The following is a description of a gene set: Genes having at least one occurrence of the motif CKSNYTAAAAAWRMCY in the regions spanning 4 kb centered on their transcription starting sites. This matches the transcription factor binding site V$MMEF2_Q6 (v7.4 TRANSFAC). Human Gene Set: MMEF2_Q6 species: Homo sapiens, and this is the list of marker genes: LINC03040, DNAJA4, BCL6, ARL4C, KLHL40, CYP26B1 (cytochrome P450 family 26 subfamily B member 1), KIRREL3, FGF13, RIMS2 (regulating synaptic membrane exocytosis 2), CRHBP, RCOR1, EHD4 (EH domain containing 4), GEN1 (GEN1 Holliday junction 5' flap endonuclease), HAS2, WFDC1, NANOS1, FXR1, COX7A2, BCL9L, EYA1, RBM8A, EBLN2, SSPN, RTP1, RTN1, MPC2, ZNF436-AS1, MYO15A, GRIK1, LINC00474, ESR1, SLC39A13, P2RX5, TLE3, RHOBTB1, FOXP2, KPNA3, ELAVL4, HOXA10, TNNC1, TENT5A, ADAM11, TYRO3, USP2, PRX, SH3BGRL3, TCTA, CKM, ARHGAP12, NOX3, MANF, CLDN14 (claudin 14), DUSP14, POU2F1, POU3F2, SLC26A9, SEMA3A, CLASP1, CACNB3, MCTP1, SLC38A3, TSPEAR, HMGB4 (NCBI Gene Id 127540), TP63, MEPCE, ARHGEF15, DMD, LRRTM1, TM2D3, DLG2, TFAP2D, DLGAP4, GAL3ST3, HS3ST5 (heparan sulfate-glucosamine 3-sulfotransferase 5), ANKMY2, CAPN1, ZNF436, ATXN7L1, USP13, MYL1, HIVEP3, CALCR, HOXD8, HIBADH, CACNA2D3, ASCL4, ZNF516-DT, TACR1, WIPI1, WDR81, NIPBL, COLQ, ASIC2, BEGAIN, LINC01597, ZCWPW1, CASQ1, IKZF2 (NCBI Gene Id 51173), NFIL3, UBE2F, HOXA4, FOXD3, H1-5, LUZP1, ACVR2A, PACSIN3, LHX9, VANGL1, TFDP2, EHD1, ADAMTS9, LRRN3, ADGRB3, LUC7L, ATL2, DNAJA2, PRKAG1, LINC00670, ABCB4, TUBA4B, TCEA3, FGF9, ACTG2, LMO3 (LIM domain only 3), DCTN1, HMGN2 (NCBI Gene Id 94860), GSC, HNRNPL, INPPL1, TLCD5, INSIG2, GCAT, ZMYND8, TSPAN14, RALY, GNB4, MYB, RBM12B, CSNK1E, CA7, ADGRL2 (NCBI Gene Id 23266), SALL3, CBFA2T2, SOBP, FILIP1, MYL11, SOX3, PDLIM1, CYB561D1, JUNB, ZPBP2, GET4, NCAN, HSPB7, VSTM2L, NRP2, KCNJ13, SALL1, PRRT2, TENM3-AS1, MYH6, ARHGAP36, FHOD1, MITF (NCBI Gene Id 7487), PIP4K2C, SLC12A5, SDC1, LYN, CHN2, MAFA, DIP2B, SIN3A, RUNX2, PPP1R16B, FOXA2, DMPK (NCBI Gene Id 60405), ADD3, BHLHE40, SSH3, ACTA1, OLIG3, PRDM13, CFL2, PENK, MAS1, HOXB8, HOXC10, TOPBP1, TUBA4A, CPS1, BNC2, CLDN23, SOX14, AMBN, MBNL2, LMX1A, BHLHE22, RFX3, MYOZ2, PTCHD4, GPR15, DBNDD2, CRTAP, STAG2, DNAJB5, ATP6V0C, DHRS3, RHOA, HSPB1, MYL6B (NCBI Gene Id 140465), GABRA1, B3GLCT, HOXD4, SLC50A1, NRAP, ZDHHC8, PRMT3, ASPH, E2F8, FAM241A (NCBI Gene Id 132720), MYL2, ELMO3, ZNF385B, NR2F1, COL11A2, SLCO2A1, GAN (NCBI Gene Id 8139), BZW2, NOG, MAB21L2, ARHGAP26, SIX3, FLRT3, ELAVL2, TOMM70, SMPX, B4GALT1, FLT1, HOXB6, PPP2R2B, MYO3B, NLK, HOXA11, CDKL5, TBR1, NEDD4, DGKI, PRKCQ, GAPDH, CDC42EP3, HTR2B, PYY2, NHLH1, PRRX1, GYPC, GPR153, SLC44A1, SV2A, DKK1, TBX4 (NCBI Gene Id 9496), RUNX1T1, HAPLN1, AGR3, RTN3 (NCBI Gene Id 95608), KLF2, MACO1, CDK14, LMCD1, TWIST2, ZBTB9, MXI1, SOX5, AICDA (activation induced cytidine deaminase), UBE3A, YPEL5